Given this list of marker genes MACROH2A2, SCMH1, H2AP, H2AC6, BMI1, METTL4, LMNB1, SIN3A, KMT2A, WT1, PCID2, HNRNPK, PCGF3, H2AC25, MAEL, MBD2, CDK2, MTA1, PPHLN1, APOBEC3B, H1-2, H2AL3 (H2A.L variant histone 3), H2AC1, EHMT2, TRIM37, SMARCA5, PIWIL2 (NCBI Gene Id 55124), BEND3 (BEN domain containing 3), HDAC1 (histone deacetylase 1), TRIM28, EZH2, CTCF, SPIN1, TPR, CIZ1, C19orf84, HDAC6, HMGA2, PIWIL1, APOBEC3G, H2AC20, SIRT7, BTBD18, KMT2D, ZNF445, LRIF1, MIS18A, DNMT3A, H3-3A, LMNA, CDKN2B-AS1, PRDM14, SMYD5, SMARCA1, UBR2, APOBEC3H (apolipoprotein B mRNA editing enzyme catalytic subunit 3H), SMCHD1, H1-0, RB1, CREBZF, METTL3, TEX15, CBX3, BRCA1, TASOR (transcription activation suppressor), BAZ2A, PARTICL, MBD1, KDM5A, MBD3L3, ZNFX1 (zinc finger NFX1-type containing 1), DDX4, H2AC21, H2AC15, H3-3B, MOV10, H2AZ1, SETDB1, MPHOSPH8, CENPV, TRIM27, MTF2, TUT4, TNP1, SUV39H1, MBD3L2B (NCBI Gene Id 729458), MBD3L2, JARID2, MORC2, CDYL, MACROH2A1, PHF1, DOT1L, LMNB2, H2AC7, YTHDC1, RRP8, SPTY2D1, EHMT1, XIST, MBD3, PPM1D, TASOR2 (NCBI Gene Id 54906), H2AX, LBR, CBX1 (chromobox 1), CHEK1, RBM15B, MYC, H2AC4, PTENP1-AS, HDAC9, H2AB3, KAT8, HDAC4, ATRX, H2AC13, TUT7, SPEN, NRDE2, EZH1, SMARCAD1, LHX2, EED, L3MBTL1, SMARCA2, HDAC5, H2AB1, SIRT1, TDRD9, TDRD1, TDRD12, H2AC12, ARB2A, BAZ1A, N6AMT1, MBD3L1, MBD3L4, UHRF1, H2AJ, APOBEC3F, HDAC3, SIRT2, H2AC11, H1-9P, PHF8, RIF1, FKBP6, ATF7IP, H2AB2, EPC1, RESF1, SUV39H2, SAMD7, MORC1, ZFP92, BCL6, MECP2, SIRT6, ING2, ZNF304, RLF, DNMT1, ARB2BP, BAHD1, USP7, UBR5, ZNF91, APOBEC3A, DNMT3L, HNRNPU, UHRF2, PCGF5, TRIP12, IFI16, BAP1, H2AC18, H2AC16, CTR9, HDAC2, TEX19, PRMT5, MBD3L5, POLE3, PHF2, H2AZ2, RBM15, PIWIL4, SPOCD1, SMARCA4, APOBEC3C, RLIM, MOV10L1, HDAC8, PHF19, TDRD5, HAT1, ZNF93, HMGB1, SDR16C5, ASZ1, DYRK1A (dual specificity tyrosine phosphorylation regulated kinase 1A), CBX5, H2AC19, H2AC17, H2AC8, SUZ12, TFAP2C, HELLS, here is a description of the gene set: species: Homo sapiens Human Gene Set: GOBP_NEGATIVE_REGULATION_OF_GENE_EXPRESSION_EPIGENETIC An epigenetic process that silences gene expression at specific genomic regions through chromatin remodeling either by modifying higher order chromatin fiber structure, nucleosomal histones, or the cytosine DNA methylation.